Given this list of marker genes Lag3, Irf8 (NCBI Gene Id 15900), Hmgb1, Slamf9, Zbtb46, here is a description of the gene set: A change in the morphology or behavior of a plasmacytoid dendritic cell resulting from exposure to an activating factor such as a cellular or soluble ligand. species: Mus musculus Mouse Gene Set: GOBP_PLASMACYTOID_DENDRITIC_CELL_ACTIVATION